Given this list of marker genes CTDP1, KIF18A, ARL8A, CENPE, MAPRE2, UNC119, PLK1, PRC1, CDCA8, INCENP, RIF1, CENPV, RACGAP1, OR2A4 (olfactory receptor family 2 subfamily A member 4), CCDC69, CDC6, FIRRM, PKP4, AURKB, EML1, AURKC, AURKA, NUMA1, MAPRE3, ARL8B, KIF14 (NCBI Gene Id 9928), BIRC5, CTTN, HNRNPU, MAP9, KIF18B, CDC42, GEM, LUZP1, RCC2 (regulator of chromosome condensation 2), MAPRE1, MAP10, KIF20B, here is a description of the gene set: Human Gene Set: GOCC_SPINDLE_MIDZONE studied in species Homo sapiens The area in the center of the spindle where the spindle microtubules from opposite poles overlap.